Given this list of marker genes ARF5, SEC22B, COG4, RAB33B, STX5, BNIP1, COPZ1, UVRAG, ERGIC3, STX18, BICD2, GBF1, ARF4, COPG2, ARF3, COG7, RAB6C, PLPP3, ATP9B (NCBI Gene Id 374868), COPE, NBAS, ARCN1, RAB6B, TMEM115, KDELR3, ATP9A, HTT, COPZ2 (NCBI Gene Id 51226), RAB6A, RAB6D, KIF1C, ERGIC2 (ERGIC and golgi 2), USE1, GOLPH3, COPB2, PITPNB, SCYL1, SCFD1, RER1, COG3, KDELR2, GOLPH3L (golgi phosphoprotein 3 like), TAPBP, RAB41, RINT1, TMED10, LMAN2, COPA, KDELR1, ERGIC1, BET1L, ZW10, here is a description of the gene set: Human Gene Set: GOBP_RETROGRADE_VESICLE_MEDIATED_TRANSPORT_GOLGI_TO_ENDOPLASMIC_RETICULUM The directed movement of substances from the Golgi back to the endoplasmic reticulum, mediated by vesicles bearing specific protein coats such as COPI or COG. species: Homo sapiens